Given this list of marker genes Nr4a3, Tardbp, Arhgef26, Mettl16, Cnst, Plekhh1, Brd1, Mrpl41, Cobll1, Mob1b, Atxn7, Hook1, Igf2r, Gpr141, Gria2, Ppm1a, Kcnn2, Tafa2, Slit2, Ppig, Lrrc7, Cadm2, Luc7l3, Arl15, Vstm2a, Rspry1, Ptpn20, Dach1, Ncoa7, Samd4b, Asb4, Camk2d, Rap2b, Tef, Thsd7a, Usp42, Ifit2, Hlcs, Prkci, Larp7, Crebzf, Rtn4, Hoxd13, Zfp703, Nrp1, Hdac9, Myh15, Map3k2, Creb1 (cAMP responsive element binding protein 1), Phf12, Dcun1d5, Yipf6, Lin28a, Pard3, Fbxo11, Fkrp, Syne2, Vsig10, Itga4, Cyrib, Col11a1, 4930558K02Rik, Myod1, Brcc3, Ppp4r2, Ggnbp2, Lix1l, Zfpm2, Cpeb3, Mthfd2, Smad2, Clec1a (C-type lectin domain family 1, member a), Elovl5, Pcdh20 (NCBI Gene Id 219257), Ube2d3, Anp32e, Agfg1, Sh3pxd2a, Zfp451, Hipk1, Cd36, Pld5, Esyt2, Sap30l, Ttll7, Tasor, Ppp2r3a, Dlx5, Lrrc18, Sema3d, Manea (NCBI Gene Id 242362), Cs, Crkl, 9430038I01Rik, Ptprj, Scai, Ttc14, Actr8, Nfatc3, Cdr1, Zfp644, Acad8, Lrif1, Fzd7, Six4, here is a description of the gene set: species: Mus musculus from publication Chen Y, Wang X (PMID 31504780) Genes predicted to be targets of miRBase v22 microRNA mmu_miR_5709_3p in miRDB v6.0 with MirTarget v4 prediction scores > 80 (high confidence targets). Mouse Gene Set: MIR_5709_3P